The following is a description of a gene set: species: Mus musculus from publication Chen Y, Wang X (PMID 31504780) Genes predicted to be targets of miRBase v22 microRNA mmu_miR_448_3p in miRDB v6.0 with MirTarget v4 prediction scores > 80 (high confidence targets). Mouse Gene Set: MIR_448_3P, and this is the list of marker genes: Uba1y, Dennd6a, Kcnv1, Fyttd1, Odf2l, Ptbp1, Hdlbp, Hecw1, Prkab2, Dpp4, Bcl11a, Grip2, Fgl2, Paxbp1, Doc2a, Acvr2a, D16Ertd472e, Bpnt2, Calr4, Rab12, Rai14, E2f3, Gatm, Amer2, Ttyh3, Kcnmb2, Slco5a1, Ube2e1, Mdga2, Fmr1, Rictor, Syn1, Cd36, Supt7l, Zswim2, Kcna4, Cxadr, Rtn4rl1, Slc7a11, Orc4, Tasor, Mpped2, Iglon5, Epha4, Cry1, Tet1, Nhsl3, Gphn (gephyrin), Dpp6, Map3k8, Irs4, Itga4, Kctd9, Cbfb, Lamp2, Daam1, Fli1, Fam168a, Cfl2, Mpc1, Zfp521, Rbm41, Rnf19a, Cpeb2, Atad2b, Kcnb1, Pof1b, Seh1l, Add1, Irx2, Caps2, Nlgn1, Cysltr1, Robo2, Plin3, Cap1, Tpk1, Phkb, Wdr72, Spast, Nrg3, Sall4, Pdk4, Satb1, Slc25a2, Themis, Map3k7, Spta1, Rab11fip2, Iqcf3 (NCBI Gene Id 68265), Tpcn1, Klhl5 (NCBI Gene Id 71778), Cntn5, Adam23, Kcnk3, Hectd2, Fgf12, Ankrd42, Zzef1, Ndst4 (NCBI Gene Id 73969), Foxd1, Otx2 (NCBI Gene Id 218991), Nim1k, Vash2, Cntnap1, Prkar2b, Sptbn4, H2bc6, Iqck, C2cd2, Nfia, Socs5, Bmal1, Slc35f4, Gan, Mknk2, Pcdha8, Mbp, Dtna, Bmpr1a, Zdhhc2, Sri, Phf3, Zfp644, Vezf1, Ank2, Naalad2, Fam184b, Glce, Pcdh8, Atosa, Pfn2, Sec23a, Rest, Nfic, Nbea, Zfp397, Sacm1l, Acbd3, Bach2, Prkcb, Amph, Tagap1 (NCBI Gene Id 380608), Naaladl2, Pgm3, Grhl3, Piga, Yipf6, Msi2, Mon2, Slc4a4, Ss18, Caprin1, Wrnip1, Arid1a, Fbxl17, Nrep, Rab3c, Hey2, Tmub2, Tcaim, Tbc1d19, Pip4p2, Ccp110, Gpr158, Fermt2, Zbtb34, Btbd8, Bcl2, Gfpt2, Rnft1, Keg1, Tmod3, Stxbp5l, Elmod1, Mbtd1, Kcnd1, Kremen1, Frem3, Glipr1l2, Krtap14, Arl13b, Txndc11, Azin1, Adgre4, Krit1, Desi2 (desumoylating isopeptidase 2), Abtb3, Dmd, Utrn, Etnk1, Zfp711, Dock9 (NCBI Gene Id 320710), Ibsp, Pgr, Sestd1, Crtc1, Itsn2, Apbb2, Arhgap25, Grb2, Braf, Spock3, Tcerg1 (transcription elongation regulator 1 (CA150)), Prmt3, Tbx3, Spry2, Syt4, Map2k6, Ednrb, Ubfd1, Adam19, Rassf6, Mfhas1, Btg3, Ceacam19, Hecw2, Btc, Neurod4, D030056L22Rik, Ncoa2, Dact1, Dnajb11, Igf1r, Calcrl, Plcb1, Ilrun, Guf1, Zfp354b, Tceal1, Tesk2, Zc3h12c, Nbl1, Fbxo33, Fbxl14, Clcn5, Ltv1, Lhfpl6, Sertad2, Rngtt, Foxo3, Sh3kbp1, Tex12, Il5, Hs3st5, Ccr5, Ero1b, Lsamp, Smurf1, Actn4, Ro60, Hif1a (NCBI Gene Id 15251), Lrrc57, Gtf3c3, Nxt2, Pcdh7, Kdsr, Dynlt3, Kctd1, Plcxd2, Stimate, Tmem170b, Unc5c, Sbno2, Ikzf1, Scn3a, Htr1f, Peli1, Pals1, Taok1, Col19a1, Wwp1, Fam168b, Tmsb4x, Pik3c2g, Zfp763, Ttc28 (tetratricopeptide repeat domain 28), Rab7 (RAB7, member RAS oncogene family), Dennd1b, Cdk19, Xylt2, Smarcd2 (SWI/SNF related, matrix associated, actin dependent regulator of chromatin, subfamily d, member 2), Tagap, Tagln3